Given this list of marker genes Mapt, Bex4, Prkaa2, Fry, Bex6, Prkaa1, Tppp, here is a description of the gene set: Any process that stops, prevents or reduces the frequency, rate or extent of tubulin deacetylation. studied in species Mus musculus Mouse Gene Set: GOBP_NEGATIVE_REGULATION_OF_TUBULIN_DEACETYLATION